Given this list of marker genes SEMA3F, CRB2, FRS2, LFNG (NCBI Gene Id 3955), MESP2, NEUROG1, MED12, NCKAP1 (NCBI Gene Id 9864), LAMA5, EPB41L5, SMAD4, ZIC3, PSEN1, CDX1, DMRT2, ABI1, HOXD8, HES5, NRP2, GDF3, BASP1, RIPPLY1, WT1, FOXB1, TDRD7, SFRP2, KAT2A, AXIN2, SEMA3C, WNT3A, NRP1, TDRKH, MSGN1, MYF5, NKX3-1, IRX2, HOXA2, TBX6, SFRP1, SHH, TCAP, NKD1, EGR2, TP53, SMAD3, XRCC2, PALB2, TAF10, CRIPTO, DCANP1, ZEB2, MLLT3, DLL3, POGLUT1, DLL1, NOTCH1, BMI1, ATM, TDRD1, RIPPLY2 (NCBI Gene Id 134701), PRKDC, IRX1, LHX1 (LIM homeobox 1), TMED2, FOXC1, TDRD6, FZD5, HES7, PPP2R3A, DKK1, IRX3, LEF1, PCDH8, MAFB, OSR1 (NCBI Gene Id 4955), FOXF1, EP300, CDX2 (NCBI Gene Id 1045), PLXNA2, TBX18, NRARP, MESP1, TBXT, PCSK6, TDRD5, TIFAB, MIB1, WNT5A, ACD, COBL (NCBI Gene Id 23242), MEOX1, RBPJ, MEOX2 (NCBI Gene Id 4223, mesenchyme homeobox 2), TBX3, POFUT1, FOXC2, DVL2 (dishevelled segment polarity protein 2), NLE1, MYF6, TASOR, MTF2, BMPR1A, TCF15, PLD6, here is a description of the gene set: Human Gene Set: GOBP_SEGMENTATION species: Homo sapiens The regionalization process that divides an organism or part of an organism into a series of semi-repetitive parts, or segments, often arranged along a longitudinal axis.